The following is a description of a gene set: Genes up-regulated in macrophages versus dendritic cells. from publication Rivollier A, He J, Kole A, Valatas V, Kelsall BL (PMID 22231304) studied in species Homo sapiens Dendritic cells (DCs) and macrophages (MPs) are important for immunological homeostasis in the colon. We found that F4/80hi CX3CR1hi (CD11b+CD103-) cells account for 80% of mouse colonic lamina propria (cLP) MHC-IIhi cells. Both CD11c+ and CD11c- cells within this population were identified as MPs based on multiple criteria, including a MP transcriptome revealed by microarray analysis. These MPs constitutively released high levels of IL-10 at least partially in response to the microbiota via an MyD88-independent mechanism. In contrast, cells expressing low to intermediate levels of F4/80 and CX3CR1 were identified as DCs, based on phenotypic and functional analysis and comprise three separate CD11chi cell populations: CD103+CX3CR1-CD11b- DCs, CD103+CX3CR1-CD11b+ DCs and CD103-CX3CR1intCD11b+ DCs. In non-inflammatory conditions, Ly6Chi monocytes differentiated primarily into CD11c+, but not CD11c- MPs. In contrast, during colitis, Ly6Chi monocytes massively invaded the colon and differentiated into pro-inflammatory CD103-CX3CR1intCD11b+ DCs, which produced high levels of IL-12, IL-23, iNOS and TNF. These findings demonstrate the dual capacity of Ly6Chi blood monocytes to differentiate into either regulatory MPs or inflammatory DCs in the colon, and that the balance of these immunologically antagonistic cell types is dictated by microenvironmental conditions. Human Gene Set: GSE27859_MACROPHAGE_VS_DC_UP, and this is the list of marker genes: SLC44A1, KPNA3, PRDM1, IGSF6, PARP14, LSM11, ACOT7, AFG2B, TMED7, CRIPTO, LDHC, TNFAIP6, VCAN (NCBI Gene Id 7902), MAPKAPK2, CERS3, DR1, CPEB4, RAPGEF2, DLD, CSF3R, TGM2, CYFIP1, RAB12, SH3TC1, CCR4, ABCC5, PTAFR, TCEA1, CERS6, IRAK2, STARD5, PABIR1, EIF2S1, MCOLN2, MIR130B, SNX10, KREMEN1 (kringle containing transmembrane protein 1), CASP7, SUCO, CCR9, ETV6, TFG, SLC39A1, HCK, RHBDF2, HSPA13, RPS6KA4, TNIP3, TRAF1, LCE1B, IL36A, PNP, SLC15A3, GPD2, SLCO3A1, SLAMF1, PPP1R15B, PLEKHO2, IKBKB, RCN1, B3GNT5, RNF31, MALT1, MARCKSL1, GABPB1, GTF2F1, SPRED1, VASP, TAP2, CWC15, CCNL1, PPP3R2, NFYB, DSTN, INTS12, DYRK2, SLC12A4, PLA1A, CEMIP2, DENR, IFNAR1, NOD2 (nucleotide binding oligomerization domain containing 2), IL27 (interleukin 27), GBP2, RCL1, NLRP3, FBXW11, HIVEP1, ABL2, MOCS1, NFAT5, SERPINE1, MAP3K8, RFFL, RAB38, ITGAV, RAB20 (NCBI Gene Id 55647), CENPT, TRIP13, ATF3, ELAVL4, EIF1, MEFV, VPS37A, SUSD2, LCP2, CCDC88B, TMX3, IKBKE (inhibitor of nuclear factor kappa B kinase subunit epsilon), F10, SMCR8, JAM2, OTUD5, TPBG, RBM7, MFSD14B (major facilitator superfamily domain containing 14B), STIP1, STXBP1, MIR222, TARM1, CRLF3, KCNH5, ADORA2B, PIK3AP1, PPP2R2A, NFKB1, YJU2B, RAB5A, YRDC, TET2, ST3GAL3, LPAR2, RAB32, CFLAR, RDH11, GSPT1, EME2, TANC1, RAN, HIVEP2, RNF144A, GBP5, ATP2A2, GCA, IRF1, CD69, TBK1, NFKBIE, ARRDC4, NLRC4, FOXP4, TRAF2, AMY1A, MED10, CXCL9, TNF, IFI16, PLK2, TANK, CCL3, TAGAP, SEC23B, TREX1, CALCRL, DAAM1, DCBLD2, PHGDH, SDC4